The following is a description of a gene set: Mouse Gene Set: CUI_MIGDC_IFNE_RESPONSE_DN Cytokines mediate cell-cell communication in the immune system and represent important therapeutic targets. A myriad of studies have highlighted their central role in immune function, yet we lack a global view of the cellular responses of each immune cell type to each cytokine. To address this gap, the authors created the Immune Dictionary, a compendium of single-cell transcriptomic profiles of more than 17 immune cell types in response to each of 86 cytokines (>1,400 cytokine-cell type combinations) in mouse lymph nodes in vivo. A cytokine-centric view of the dictionary revealed that most cytokines induce highly cell-type-specific responses. For example, the inflammatory cytokine interleukin-1β induces distinct gene programmes in almost every cell type. A cell-type-centric view of the dictionary identified more than 66 cytokine-driven cellular polarization states across immune cell types, including previously uncharacterized states such as an interleukin-18-induced polyfunctional natural killer cell state. species: Mus musculus from publication Cui A, Huang T, Li S, Ma A, Pérez JL, Sander C, Keskin DB, Wu CJ, Fraenkel E, Hacohen N (PMID 38057668) Genes negatively differentially expressed in cell type: MigDC (migratory dendritic cell) upon treatment with cytokine: IFN-ε in mouse lymph nodes in vivo., and this is the list of marker genes: Fos, Hspa1a, Uba52, Hspa1b, Jun